Given this list of marker genes H2BC14, CENPF, RHOA, ITGB3BP, TAX1BP3, PPP2R5B, PIK3C3, PAK1, PTK2, SGO1, CENPN, H3C1, PAFAH1B1, DYNLL1, PRC1, KIF2B, WASF3, CLIP1, SFN, KTN1, INCENP, NUP107 (NCBI Gene Id 57122), NCKAP1, CLASP2, KLC4, CYFIP2, NCKAP1L, RHOQ, DYNC1I1, MIS12, H2AX, NOXO1, KIF18A, CTNNA1, MYL9, RPS27, MYH11, H2AZ2, CENPK, DYNLL2, H2AC7, DIAPH2, KDM4C, PPP2CB, TUBB3, ABI1, DYNC1I2, H2AB1, CENPI, CYBA, RHOG (NCBI Gene Id 391), RHOC, PPP2R1B, DYNC1LI1, PRKCD, NCF4, TUBB8B, MAPK3, NUP37, PPP2R5D, MAD1L1, SEC13, TAOK1, RHOD, H2AC20, SRF, B9D2, CTTN, PKN1, CENPU, H2BC3 (H2B clustered histone 3), TUBA4B, CENPO, WASF2, NDEL1 (nudE neurodevelopment protein 1 like 1), TUBA3C, SKA1, CFL1, NUDC, GOPC, CFTR, H2AJ, H2BC9, SGO2, RHPN2, IQGAP1, KNTC1 (kinetochore associated 1), ZW10, IQGAP3, MAPK1, BUB1, KDM1A, H3C15, CDKN1B, KLK2, NOX1, NCKIPSD, NUP43, TUBAL3, RHOB, YWHAB, H2AC18, PRKCB, H2BC21 (H2B clustered histone 21), SKA2, DVL1, DVL2, BUB1B, DIAPH3, ACTR2, PKN3, TUBB4B, ACTB, DIAPH1, H2BC15, CDCA8, ARPC4, PIK3R4, TUBB1, NCK1, CDC20, PPP1R12B, KIF5B, SRGAP2, SPC24, ARPC5, ROPN1, MAD2L1, H2BC12, TUBB4A, RTKN, PKN2, TUBA4A, KIF5A (kinesin family member 5A), RAC2 (Rac family small GTPase 2), PFN2, RHPN1, RANGAP1, ARPC1A, BUB3, TUBB6, CENPH, CKAP5, NCF2, PPP2R1A, TUBA1A, LIN7B, FLNA, NUP98, CDC25C, IQGAP2, S100A9, BAIAP2, MYH14, H2AC4, RANBP2, ABI2, YWHAG, ARPC3, CENPT, MEN1, H2BC5, CYBB, ARPC2, FMNL2, CENPP, CDH1, NDC80, WASL, CENPA, H2BC1, NSL1, CENPM, MYL12B, LIMK2, NCOA2, PRKCZ, AR, NDE1, H2BC4, SPC25, MAPRE1, CENPQ, H4C1, TUBA1B, H2BC11, NOXA1, YWHAZ, CALM1, PIN1, RAC1, KLK3, NOX3, H2BC26, YWHAH, RCC2, KLC2, NUP133, DLG4, SCAI, BTK, XPO1, ZWINT, PPP1R14A, PPP1CC, ERCC6L, DYNC1LI2, CENPE, SEH1L, CENPC, PFN1, PDPK1, NUP85, PPP2CA, CLASP1 (NCBI Gene Id 23332), EVL, ZWILCH, PRKCA, KIF2A, H2BC17, SRC, KNL1, CENPL, DVL3, H3-3A, BIRC5, ACTG1, S100A8, ROCK1, FMNL1, TUBB2B, WASF1, PAK2, LIMK1, PPP2R5E, ITGB1, AHCTF1, FMNL3, MAPK11, H2AC6, NCF1, H2BC13, ACTR3, CENPS (NCBI Gene Id 378708), MYH9, CDC42, PPP1CB, KIF2C, KLC3, TUBB2A, WIPF1, PAK3, PPP1R12A, NUP160, CYFIP1, KIF14, DYNC1H1, PPP2R5C, TUBA3D, ROCK2, MRTFA, PLK1, H2BC12L, TUBA8, WIPF2, ARPC1B, H2AC14, MYL6, NF2, CTNNB1, TUBA1C, MYH10, YWHAQ, TUBA3E, WAS, MYLK, KLC1, PPP2R5A, NUF2, DSN1, BRK1, PMF1, WIPF3, YWHAE (tyrosine 3-monooxygenase/tryptophan 5-monooxygenase activation protein epsilon), TUBB8, MAPK14, SPDL1, CIT, GRB2, DAAM1, AURKB, ABL1, here is a description of the gene set: RHO GTPases regulate cell behaviour by activating a number of downstream effectors that regulate cytoskeletal organization, intracellular trafficking and transcription.<p>One of the best studied RHO GTPase effectors are protein kinases ROCK1 and ROCK2, which are activated by binding RHOA, RHOB or RHOC. ROCK1 and ROCK2 phosphorylate many proteins involved in the stabilization of actin filaments and generation of actin-myosin contractile force, such as LIM kinases and myosin regulatory light chains (MRLC).<p>PAK1, PAK2 and PAK3, members of the p21-activated kinase family, are activated by binding to RHO GTPases RAC1 and CDC42 and subsequent autophosphorylation and are involved in cytoskeleton regulation.<p>RHOA, RHOB, RHOC and RAC1 activate protein kinase C related kinases (PKNs) PKN1, PKN2 and PKN3, bringing them in proximity to the PIP3-activated PDPK1 (PDK1) and thus enabling PDPK1-mediated phosphorylation of PKN1, PKN2 and PKN3. PKNs play important roles in cytoskeleton organization, regulation of cell cycle, receptor trafficking and apoptosis. PKN1 is also involved in the ligand-dependent transcriptional activation by the androgen receptor.<p>Citron kinase (CIT) binds RHO GTPases RHOA, RHOB, RHOC and RAC1, but the mechanism of CIT activation by GTP-bound RHO GTPases has not been elucidated. CIT and RHOA are implicated to act together in Golgi apparatus organization through regulation of the actin cytoskeleton. CIT is also involved in the regulation of cytokinesis through its interaction with KIF14.<p>RHOA, RHOG, RAC1 and CDC42 bind kinectin (KTN1), a kinesin anchor protein involved in kinesin-mediated vesicle motility. The effect of RHOG activity on cellular morphology, exhibited in the formation of microtubule-dependent cellular protrusions, depends both on RHOG interaction with KTN1, as well as on the kinesin activity. RHOG and KTN1 also cooperate in microtubule-dependent lysosomal transport.<p>IQGAP proteins IQGAP1, IQGAP2 and IQGAP3, bind RAC1 and CDC42 and stabilize them in their GTP-bound state. IQGAPs bind F-actin filaments and modulate cell shape and motility through regulation of G-actin/F-actin equilibrium. Binding of IQGAPs to F-actin is inhibited by calmodulin. IQGAP1 is involved in the regulation of adherens junctions through its interaction with E-cadherin (CDH1) and catenins (CTTNB1 and CTTNA1). IQGAP1 contributes to cell polarity and lamellipodia formation through its interaction with microtubules.<p>RHOQ (TC10) regulates the trafficking of CFTR (cystic fibrosis transmembrane conductance regulator) by binding to the Golgi-associated protein GOPC (also known as PIST, FIG and CAL). In the absence of RHOQ, GOPC bound to CFTR directs CFTR for lysosomal degradation, while GTP-bound RHOQ directs GOPC:CFTR complex to the plasma membrane, thereby rescuing CFTR.<p>RAC1 and CDC42 activate WASP and WAVE proteins, members of the Wiskott-Aldrich Syndrome protein family. WASPs and WAVEs simultaneously interact with G-actin and the actin-related ARP2/3 complex, acting as nucleation promoting factors in actin polymerization.<p>RHOA, RHOB, RHOC, RAC1 and CDC42 activate a subset of formin family members. Once activated, formins bind G-actin and the actin-bound profilins and accelerate actin polymerization, while some formins also interact with microtubules. Formin-mediated cytoskeletal reorganization plays important roles in cell motility, organelle trafficking and mitosis.<p>Rhotekin (RTKN) and rhophilins (RHPN1 and RHPN2) are effectors of RHOA, RHOB and RHOC and have not been studied in detail. They regulate the organization of the actin cytoskeleton and are implicated in the establishment of cell polarity, cell motility and possibly endosome trafficking. Similar to formins, cytoskeletal changes triggered by RTKN activation may lead to stimulation of SRF-mediated transcription.<p>RHO GTPases RAC1 and RAC2 are needed for activation of NADPH oxidase complexes 1, 2 and 3 (NOX1, NOX2 and NOX3), membrane associated enzymatic complexes that use NADPH as an electron donor to reduce oxygen and produce superoxide (O2-). Superoxide serves as a secondary messenger and also directly contributes to the microbicidal activity of neutrophils. Reactome Pathway: RHO GTPase Effectors studied in species Homo sapiens part of: Signaling by Rho GTPases